Given this list of marker genes Bmp4, Pdgfra, Pdgfrb, Notch2, Notch3, Tcf21, here is a description of the gene set: Mouse Gene Set: GOBP_GLOMERULUS_VASCULATURE_MORPHOGENESIS The process in which the anatomical structures of the glomerulus vasculature are generated and organized. The glomerulus vasculature is composed of the tubule structures that carry blood or lymph in the glomerulus. studied in species Mus musculus